The following is a description of a gene set: Metrorrhagia Bleeding at irregular intervals. Human Gene Set: HP_METRORRHAGIA species: Homo sapiens, and this is the list of marker genes: FLI1, ZBTB16, BCOR, STAT3, RARA, NUMA1, PRKAR1A, NABP1, IRF2BP2, NPM1, STAT5B, FIP1L1, HPS5, PML, F5, TBL1XR1